The following is a description of a gene set: from publication Chen Y, Wang X (PMID 31504780) Mouse Gene Set: MIR_10A_3P Genes predicted to be targets of miRBase v22 microRNA mmu_miR_10a_3p in miRDB v6.0 with MirTarget v4 prediction scores > 80 (high confidence targets). species: Mus musculus, and this is the list of marker genes: Elmod2, Sult2a8, Tmem33, Birc6 (baculoviral IAP repeat-containing 6), Arpp21, Prdm16 (PR domain containing 16), Zdhhc21, Hoxc4, Plagl1, Krtap16-3, Plcb1, Nxph1, Reps2, Rufy2